Given this list of marker genes AQP8, MBTPS1, SEC14L2, PRKACA, HMGCS2, SQLE, ACLY, APOE, CYP51A1 (NCBI Gene Id 1595), MIR342, QKI, FDFT1, SREBF1, LBR, GPR146, EBP, FAXDC2, ABCA2, MIR98, APOA1 (NCBI Gene Id 335), KPNB1, MSMO1, ERLIN2, PRKAA2, CYB5R1, MAPK1, ACAA2, PRKAG2, MIR182, SREBF2, CYB5R2, ARV1, SC5D, CES1, PMVK, LPCAT3, MIR30C1, FDPS, ERLIN1, SCAP, ABCG4, NPC1L1, NSDHL, GNAI1, CYP7A1 (cytochrome P450 family 7 subfamily A member 1), ERG28, DHCR24, MIR185, PAQR3, LIPA, PRKAA1, C7orf50, ABCG1, HSD17B7, G6PD, MVD, DHCR7, IDI2, MIR96, IDI1, CH25H, LSS, APOB, INSIG2, MVK, HMGCS1, FGF1, INSIG1, PLPP6, MBTPS2, HMGCR, CFTR, TM7SF2, MIR548P, CYB5R3, here is a description of the gene set: The chemical reactions and pathways resulting in the formation of sterols, steroids with one or more hydroxyl groups and a hydrocarbon side-chain in the molecule. Human Gene Set: GOBP_STEROL_BIOSYNTHETIC_PROCESS studied in species Homo sapiens